Given this list of marker genes SVBP, LBR, TBX3, FLNA, GNAS, here is a description of the gene set: Human Gene Set: HP_ABNORMAL_3RD_METACARPAL_MORPHOLOGY Any abnormality of the third metacarpal bone. species: Homo sapiens Abnormal 3rd metacarpal morphology